Given this list of marker genes PTF1A, ERCC8, H4C5, TOP3A, PIK3R1, ATP6V1A (ATPase H+ transporting V1 subunit A), SOX18, BSCL2, TGFB1 (NCBI Gene Id 7040), LMNA, INSR, ERCC6, SKI, GNB2, KCNJ6, NAA10, PPARG, SLC25A24, KCNK9, CYP27B1, RBM28, ATP6V1E1, POLR3A, AGPAT2, FBN1, CAV1, ZMPSTE24, LEMD2, IGF1R, FH, SLC2A2, TGFB3, PLIN1, here is a description of the gene set: A reduced amount of fat tissue in the lowest layer of the integument. This feature can be appreciated by a reduced skinfold thickness. Human Gene Set: HP_REDUCED_SUBCUTANEOUS_ADIPOSE_TISSUE Reduced subcutaneous adipose tissue studied in species Homo sapiens